Given this list of marker genes Ubfd1, Adam22, Necab1, Pax2, Fzd3, Eif4h, Csf3r, Mapk8ip2, Cul3, Slk, Ranbp6 (RAN binding protein 6), Lgi3, Mapre1, Cyb5r2, Ube3c, Necap2, Fkbp14, Slc46a1, Eif4g2, Erc1, Mecp2, Cep57l1, Pex13, Zfp420, Tnks, Cdca5, Acat2, Cnot7, Srr, Stx16, Slc44a5, Cplx4, Map3k9, Ybey, Copz1, Strbp (NCBI Gene Id 99105), Itsn2, Adamts17, Sdhd, Gpr34, Yap1, Apex2, Dsel, Zbtb43, Clec16a, Slc22a23, Serpini1, Ppp2r2c, Zfp169, Msl3, Tsr1, Arl15, Ccdc91, Col6a1, Hpcal4, Cacna1c, Zfp92, Ccl4, Efcab11, Rmnd5a, Adam15, Ikzf2, Ms4a6b, Pcgf3, Pcdhb22, Map1b, Jph3, Uba5, Keap1, Ccnb1ip1, Zmat3, Slc38a8, E230025N22Rik, Vsx2, Ano5, Tead4, Rnf111, Zbtb34, Traf3, Rhobtb3, Gdf15, Fbxl7, Pou2af1, Ms4a6c, Msx2, Fhip2b, Glrp1, Man1a, Ereg, Ubl4b, Gmfb, Dock5, Cnpy1, Atxn1l, Nploc4, Bmx, Tspyl5, Gpr85, Spata3, Pm20d2 (NCBI Gene Id 242377), Pnp, Kpna6, Plp2, Cyp3a11, St6galnac3, Nat8l, Pam, Zfp26, Loxl4, St3gal5, Gria3, Slc24a5, Myef2, Il13ra1, Ttc17, Spidr, Igsf9b, Appl1, Nrxn2, Cbfa2t3, Fgf13, Pcdhb13, Usp14, Cnot6l, Copa, Svip, Synpo2l, Kdm5a, Lrrfip1, Fbln7, Gabarapl1, Pfdn2, Vegfa, Ski, Cyb561a3, here is a description of the gene set: from publication Chen Y, Wang X (PMID 31504780) Mouse Gene Set: MIR_6969_5P studied in species Mus musculus Genes predicted to be targets of miRBase v22 microRNA mmu_miR_6969_5p in miRDB v6.0 with MirTarget v4 prediction scores > 80 (high confidence targets).